The following is a description of a gene set: studied in species Homo sapiens The chemical reactions and pathways involving heme b, a Fe(II) porphyrin complex readily isolated from the hemoglobin of beef blood, but also found in other proteins including other hemoglobins, myoglobins, cytochromes P-450, catalases, peroxidases as well as b type cytochromes. Human Gene Set: GOBP_HEME_B_METABOLIC_PROCESS, and this is the list of marker genes: UROS, FECH, ALAS1, CPOX (NCBI Gene Id 201541), ALAD, ALAS2, ABCB6, PPOX (NCBI Gene Id 7440), HMBS, UROD